Given this list of marker genes PHOX2B, SOX10, RET, SLC6A4, SOX8, TLX2, GDNF, EDNRA, HLX, KIF26A, PHACTR4 (phosphatase and actin regulator 4), EDNRB, here is a description of the gene set: studied in species Homo sapiens The process whose specific outcome is the progression of the enteric nervous system over time, from its formation to the mature structure. The enteric nervous system is composed of two ganglionated neural plexuses in the gut wall which form one of the three major divisions of the autonomic nervous system. The enteric nervous system innervates the gastrointestinal tract, the pancreas, and the gallbladder. It contains sensory neurons, interneurons, and motor neurons. Thus the circuitry can autonomously sense the tension and the chemical environment in the gut and regulate blood vessel tone, motility, secretions, and fluid transport. The system is itself governed by the central nervous system and receives both parasympathetic and sympathetic innervation. Human Gene Set: GOBP_ENTERIC_NERVOUS_SYSTEM_DEVELOPMENT